The following is a description of a gene set: studied in species Mus musculus Mouse Gene Set: GOMF_OXO_ACID_LYASE_ACTIVITY Catalysis of the cleavage of a C-C bond by other means than by hydrolysis or oxidation, of a 3-hydroxy acid., and this is the list of marker genes: Clybl, Npl, Hmgcll1, Hmgcl, Tyw1, Hoga1